Given this list of marker genes CNPY3, CTBP2, AKAP13 (NCBI Gene Id 84122), TESC, AGTPBP1, RHBDF2, SERPINA1, USP3, PELI1, IGF1R, RPL30, CCS, PISD, FAM216A, CRISPLD2, NHERF1, MEGF9, BTG1, ELK3, CNNM3, NACA4P, NUP214, IRS2, PLXNC1, RPS27A, TMEM131L, LYN (NCBI Gene Id 4067), BCL11A, NOD2, NOP53, LYST, S100A9, CIDEB, SELL, ADGRE5, PLSCR1, CEBPD, CAMKK2, CSF3R, BTN3A3, CKAP4, PDP1, RPL14, SP110 (SP110 nuclear body protein), NCF1C, NADK, MTMR3, ZBTB18, CCDC88C, LILRB1, TNFRSF1B, HSD17B11, OGG1, RAP1GAP2, BTN3A1, ADAM8, FYN, F5, RGS2, PNOC, LINC00623, LILRA2, STK10, CORO1A, IER2, ITGA4, U2AF1, IL15, FPR1, ING1, SMPDL3A, HEBP2, KLF6, KLF13, EIF3M, BPI, AP1S2, PSMB10, NFE2 (NCBI Gene Id 4778), GCH1, BICRAL, DUSP6, PTPN2, CX3CR1, KLF4, AKAP9, C1GALT1, KLF2, PMAIP1, RIN3, TNFSF10, BLTP1, PLP2, EEF1D (eukaryotic translation elongation factor 1 delta), METTL9, ARHGAP26, CSTA, ZDHHC17, IRAK3, HPSE, GMEB1, ZNF395, CD244, CDKN2D, RPS6, SP100, LILRB3, RPS6KA5, MYCBP2, PIK3CD, GPSM3, TLR5, MTMR11, VCAN, CFP, MYO1F, USE1, IRF7, THEMIS2, CHD1, GABPB1-IT1, FCN1, IL6R, TCF7L2, CD37, KCNJ15, CHST15, FOS, IFITM2, GADD45B, NOTCH2, CD55, C15orf39, TSC22D3, N4BP2L2, SLC11A1, NUP50, ATP13A2 (ATPase cation transporting 13A2), NAALADL1, LILRA3 (leukocyte immunoglobulin like receptor A3), CD1D, MTSS1, CREBBP, MCUB, P2RY2, FAM204A, SEMA4D, APOBEC3A, TLR2, PTP4A2, CDC42EP3, GSDMD, S100A12, EXT1, NBEAL2, SIK3, LAT2, PSTPIP1, NOTCH2NLA, SLC16A7, NEDD9, DUSP1, LILRB2, RPS7, GCA, CD14, CD48, PID1, HLA-F (NCBI Gene Id 3134), RIPOR2, STK38, ADGRE1, GBP2, SIGLEC5, FAU (NCBI Gene Id 55430), SMC5, TGIF2, CASP1, IRF1 (interferon regulatory factor 1), ZFP36, APOL3, CD93, GRAMD1B, FLOT1, ITGAL, CD300A, RAB27A, MCL1, LILRA1, INPP5A, MAP2K3 (NCBI Gene Id 92079), CNTRL, CFD, VNN2, NLRP1, ING3, CRLF3, SLC7A7, ICAM2, WDR45, here is a description of the gene set: Human Gene Set: GSE22886_DC_VS_MONOCYTE_DN Immune cell-specific expression is one indication of the importance of a gene's role in the immune response. In order to identify such patterns, we set out to broadly profile gene expression in a variety of immune cells. studied in species Homo sapiens from publication Abbas AR, Baldwin D, Ma Y, Ouyang W, Gurney A, Martin F, Fong S, van Lookeren Campagne M, Godowski P, Williams PM, Chan AC, Clark HF (PMID 15789058) Genes down-regulated in comparison of dendritic cells (DC) versus monocytes.